Given this list of marker genes MSH6, MSH3, MSH2, here is a description of the gene set: part of: Diseases of Mismatch Repair (MMR) MSH2 is homologous to the E. coli MutS gene and is involved in DNA mismatch repair (MMR). Heterozygous mutations in the MSH2 gene result in hereditary nonpolyposis colorectal cancer-1. Variants of MSH2 are associated with hereditary nonpolyposis colorectal cancer. Alteration of MSH2 is also involved in Muir-Torre syndrome and mismatch repair cancer syndrome. Reactome Pathway: Defective Mismatch Repair Associated With MSH2 species: Homo sapiens